Given this list of marker genes NTM, NFIB, ADAM10, PLEKHA5, CD44, ADM5, NBPF15, PCDH7, PRDM16, RIMS1, DOK6 (NCBI Gene Id 220164), A1CF, NBPF14, ZFHX4, NBPF9, NYAP2, CCL28, NBPF12, DUSP14, DNAJC13, EFHC1, WDR37, ZNF398, TTC39B (tetratricopeptide repeat domain 39B), CGNL1, PNPLA5, EIF2S1, DUSP4, L3MBTL3, TIMM17A, MGAT5B, ZNF716, SPDYE5, PDGFA, ABO, PALM2AKAP2, IFT70B, DPP3, RAP2C, ZBTB10, SAMD13, OSTC, SLC35F5, TMEM11, NOTUM, PRKCB, GLT6D1, SLC16A7, TRIB2, PRKCH, RBMS2, PNISR, ZNF737, RPS23, RFPL4B, LRRC10, SHISA7, ARHGEF38, GATA5, THSD7A, SORCS2, FCGR1BP (NCBI Gene Id 440607), OLIG3, NPDC1, ADGRG6, OPRM1, CTBP2 (C-terminal binding protein 2), BAMBI, CD164, BCORL1, CLDN8, KCNC1, CD3G, CASZ1, EYA1, KDM8, ZNF609, ERBB4, ZNF329, CAMKK2, NBPF11, PPP4R3B, RTN1, PTPRR, SPDYE6, PCSK5, ARSA, LARP7, GABRA4, AMMECR1, NHLH2, FOXD4L5, BRINP2, BDNF, NBPF20, MCC, DMRT3 (doublesex and mab-3 related transcription factor 3), PKIA, ARID4B, ASH1L, KLHL23, FCGR1A, FOXN2, CATSPERE, NBPF1, ADGRF1, FZD7, HRH3, GATA2, OTX2 (orthodenticle homeobox 2), PTPRT, BHLHE22, SLC35D3, TMEM231, FAM91A1, SLC30A8, RLN2, GPM6A, ZMYND19, NBPF8, DOCK5, GADD45B, MAP7D3, CREM, MED14, AIG1, RNF212, here is a description of the gene set: Human Gene Set: MIR6818_3P studied in species Homo sapiens from publication Chen Y, Wang X (PMID 31504780) Genes predicted to be targets of miRBase v22 microRNA hsa-miR-6818-3p in miRDB v6.0 with MirTarget v4 prediction scores > 80 (high confidence targets).